The following is a description of a gene set: Human Gene Set: GSE22886_NAIVE_BCELL_VS_BLOOD_PLASMA_CELL_UP Immune cell-specific expression is one indication of the importance of a gene's role in the immune response. In order to identify such patterns, we set out to broadly profile gene expression in a variety of immune cells. studied in species Homo sapiens Genes up-regulated in comparison of naive B cells versus blood plasma cells. from publication Abbas AR, Baldwin D, Ma Y, Ouyang W, Gurney A, Martin F, Fong S, van Lookeren Campagne M, Godowski P, Williams PM, Chan AC, Clark HF (PMID 15789058), and this is the list of marker genes: CD84, LY86, ETS2, SLC7A6, SP1, GTPBP2, SORL1, DDX60, DCAF8, FBXO42, HGSNAT, ARHGAP32, KAT6A, VAV3, SCLY, ITPKB, CD22, FBXO4, FAM53B, MS4A1, SIN3B, DUSP1, GIN1, CD69, SPRY4, ZFP36L1, GRK3, TTBK2, TSPYL5, GPM6A, ARAP2 (ArfGAP with RhoGAP domain, ankyrin repeat and PH domain 2), UST, TBC1D5, LARS1, GNG11, POU6F1, TEP1, HPS1, DENND4B (NCBI Gene Id 9909), FMO5, PDE10A, PER1, COX16, DBNDD1, AMT, PIK3CD, HLA-DOB (major histocompatibility complex, class II, DO beta), RGL2, BRD3, NR3C2, ZNF862, LAPTM5, ANKFY1, ASB1, KLF7, CEP68, ZNF532, ARHGAP19 (NCBI Gene Id 84986), MTMR9, LYST, PBX3, CPB1, CHL1, SOBP, RETREG1, TRMT2B, ATAD2B, PKIG, SLC6A16 (solute carrier family 6 member 16), DDR1, SMAD3 (SMAD family member 3), DLG5, NREP, RPS27, DTX4, INTS9, FGF7, MMP2, AGBL2, UTP25, MLLT10, KHNYN, NHLRC2, STX6, TBC1D13, RAPGEF6, HERC3, CRYBG1, ZNF264, IRF8, SLA, SPG7 (SPG7 matrix AAA peptidase subunit, paraplegin), RADX, C1QTNF1, CLCN4, DUSP10, RBM8A, DCAF17, CNR2 (cannabinoid receptor 2), CLEC7A, AP3M2, KLRB1, ZNF112, PARP16, ZNF136, MTMR10, RPS23, CR2, KLHL3, HLA-DMB, SEMA4F, SMURF1, TRPS1, ENGASE, CEP164, CD83, DYM, TCL1A, NBPF10, PVRIG, RALGPS1, DPPA4, HLA-DPA1, POLR1HASP, PHC1, CBLB, GSTA1, GARRE1, UTRN, ZNF606, POLM, XYLT1, SCML2, DNAJC16, CORO2B, CDK19, STAT6, LRIG2, MVK, ENDOD1, CD200, PRMT2, BTG1, APBB1IP, SOS2, ABCC5, TNFSF12 (NCBI Gene Id 8742), OTUD3, PHLPP2, DSTYK, STRN3, TSC22D3, BANK1, HLA-DRA, TRIM22, KLF9, ARIH1, FAM131A, LBH, PRKY, NOD1, CLEC4A, IL24, MX2, GABBR1, PTGS1, KDM6B, SLC12A7, ENTPD1-AS1 (ENTPD1 antisense RNA 1), FCMR, CD72, CEP43, IL4R, ASAP1, ACTR3B, CXCR4, HLA-DPB1 (NCBI Gene Id 3115), HLA-DRB1, SELL, LTB, DUSP6, TRAF5, ZNF43, SLC25A16, WDR48, GSTA4, VAV2, ZNF211, PEG10, PHKA2, OBI1, MMD, TSPYL2, ZNF571, ZCCHC2, RNF44, GPRASP1, MNT, TGIF1, PTPRK